The following is a description of a gene set: Human Gene Set: MIR6715B_5P studied in species Homo sapiens from publication Chen Y, Wang X (PMID 31504780) Genes predicted to be targets of miRBase v22 microRNA hsa-miR-6715b-5p in miRDB v6.0 with MirTarget v4 prediction scores > 80 (high confidence targets)., and this is the list of marker genes: SIPA1L2, NPLOC4, KRTAP26-1, LMAN2L, CTTNBP2NL, DSG1, PRKAR2A, APP, SEPTIN2, UHRF2, VWA5B2, QRICH1, SLC39A10, HIF1AN, ZNF585A, CLCN3, GRK2, PGAP1, SENP8, TRPS1, TAOK3, SOX8, SCN2A, TRIM9, KANK1, CETN2, ZEB1, JARID2, PTK7, MCC, SNX30, DVL2, PLEKHA1, POLE3, NMNAT2, SCN4B, ACVR1B, PRX, ARAF (NCBI Gene Id 369), CKS2, DNM2, TMEM248, ZEB2, CYB561D1, ATXN7, KCNIP1, ATG4A, EIF4H, GIT2, ROBO2, CSDE1, SLC44A1, E2F3 (E2F transcription factor 3), OSBPL11, RGS7BP, SERPINI2, ZNF436, LANCL2, DNMBP, LMAN1, WNT8A, OTUD7A, PCSK7, CSMD2, TMEM214, TFDP1, FASLG, ZNF608, RPL7L1 (NCBI Gene Id 285855), KCNMB1, ZNF688, SUCLG1, SRPRA, BTBD7, KCND3, RHOB, JPH3, SCN3A, ESR1, RFX3, PPM1B, LRCH2, HIPK3, MYO18A, DOCK11, BCL7A, TDRP (testis development related protein), PDE7A, LMNA, BRWD1, KIF21B, ARVCF, PPIF, JAZF1, ERF, MYPOP, ARHGAP28, RAD21, BTK, RAB33A, GARIN6, ARK2C, CEP164, IRGQ, MAGI1, UBL3, CYBC1, FOXO1, DLST, U2SURP, GET1-SH3BGR, FAM167A, CTNNB1, SMARCD1, AKAP6, ANKS6, TUSC1, NWD1, MEOX2, SDC3 (NCBI Gene Id 9672), SPRED2, KANSL1, KPNA4, TENT5A, DNAAF9, SERPINA1, XYLT2, CREB1, AFG2B, ACCS, PLXNC1, SEH1L, GPCPD1, CDC20B, KIF16B, PHF21A, MTCL1, MAPKAPK3, UBE2K, GNB4, TEAD1, USP12, ZFAND5, CRBN, ABLIM3, RNF123, ZBTB22, AHSG, RMND5A, CSNK1G3, MAP2, PFN2, WDFY3, MLEC, GNPDA1, IGDCC4, STK39, HOXD1, CREB5, TOGARAM1, PAFAH1B1, EIF5B, MTSS1, RASA2, LDLR, UBFD1, UBE3C, FAT1, RAB8A, APPL2, RIMS3, PEX13, FZD1, ERGIC2, FBXL18, ESYT2, PPP4R2 (protein phosphatase 4 regulatory subunit 2), ZFYVE16, TIMP3, NAA20, RSBN1L, MIDEAS, SPINT3, GATAD2A, CAST, ETF1, THY1, GAREM1, ZDHHC17, HP1BP3, TLN1, KCTD6, REEP3, MAPK8IP2, HEY2, MYORG, RBPJ, MGAT4B, MORC2, CREBZF, UBE4B, SV2B, ALDH1L2, ADCY3, SORT1, MED28, TSHZ2, MINDY2, GPR63, TMEM64, SH3BGR, PTGDR2, CACNA1B, CAV1, C11orf68, SKI, UBTD2, SLAIN1, GRIN2A, KCNH8, HNF4G, FAM161B